The following is a description of a gene set: studied in species Homo sapiens Autophagy Human Gene Set: REACTOME_AUTOPHAGY, and this is the list of marker genes: UBA52, EPAS1, VDAC3, GABARAP, PLIN3, RRAGB, HSF1, DYNC1I2, HSP90AA1, TUBB6, VDAC2, PGAM5, CHMP3, SRC, ARL13B, ATG4A, TUBB8B, PRKAA1, PLIN2, TOMM6, TSC2, TUBAL3, WIPI2, PRKAG3, ATG16L2, LAMTOR5, CHMP7, CFTR, PARK7, VCP, TUBB4B, ATG4C, DYNC1LI1, UBAP1, UVRAG, CSNK2B, HDAC6, TUBA1B, TUBB1, DYNLL1, RRAGD (Ras related GTP binding D), OPTN, VPS37B (VPS37B subunit of ESCRT-I), ATG13, HBB, TOMM22, MTMR14, TUBB8, ATG16L1, FUNDC1, TUBA3D (NCBI Gene Id 150778), TUBA1C, LAMP2, RPTOR, TUBB2A, ATG9B, TUBA1A, MTOR, TOMM7, ATG10, PRKAB2, CETN1, ATG14, RRAGA, PRKN, CSNK2A2, LAMTOR2, NBR1, UBC, MFN2, CHMP2B, MAP1LC3A, LAMTOR1, WIPI1, PIK3C3, UBE2N, CHMP4A, TUBA8, WDR45B, HSP90AB1, IFT88, LAMTOR3, VDAC1, EEF1A1, VPS37D, RB1CC1, MLST8, MVB12B, UBE2L3, PRKAG1, CHMP6, ATG5, HSPA8, USP30, CHMP4B, RPS27A, TOMM5, ATG3, MAP1LC3C, ATG7, TUBB2B, GFAP, TUBA4B, TOMM20, MTERF3, ATG4D, ULK1, UBE2D2, TOMM40, MTMR3, PCNT, MAP1LC3B, AMBRA1, PRKAA2, MVB12A, ATG4B, BECN1, TBK1, DYNC1LI2, TOMM70, SLC38A9, TUBB3, SQSTM1, WDR45, GABARAPL2, TUBA3C, UBE2D3, ATG101, TSG101, PRKAG2, LAMTOR4, TUBA4A, ATM, DYNC1H1, CHMP2A, PRKAB1, UBE2V1, MFN1, GABARAPL1, UBB, VPS37C, VPS28, TUBB4A, CHMP4C, RHEB (NCBI Gene Id 6009), TSC1, ATG9A, CSNK2A1, VPS37A, RNASE1, PINK1 (PTEN induced kinase 1), RRAGC, TUBA3E, PIK3R4, ATG12 (NCBI Gene Id 9140), DYNLL2, DYNC1I1, VIM, PEX5